The following is a description of a gene set: species: Homo sapiens Human Gene Set: GOMF_OXIDOREDUCTASE_ACTIVITY_ACTING_ON_CH_OH_GROUP_OF_DONORS Catalysis of an oxidation-reduction (redox) reaction in which a CH-OH group act as a hydrogen or electron donor and reduces a hydrogen or electron acceptor., and this is the list of marker genes: CBR3 (NCBI Gene Id 874), AKR7A2, EHHADH, RDH16, SORD, UEVLD, HSD3B2, DHRS3, NSDHL, HADHB, HSD17B1, UGDH, RDH10, ADH7, DHRS1, HSD17B8, HPGD, L2HGDH, SDR16C5, ADH1A, LDHAL6A, BDH2, CYP4F3, HIBADH, HAO1 (hydroxyacid oxidase 1), PTGR1, IDH2, CYP4F2, DHRS9, CBR4, HSD11B2, IDH3G, DHRS4L2, MDH2, ME1, ADH1C, HSD17B3, BDH1, ADH6, ADH5, KCNAB3, HSD17B10, DHRS4L1, IDH1, HSD3B1, AKR1B10, PGD, H6PD, IDH3A, IMPDH2, DHDH, GPD1, ALDH3A2, RDH13, GPD2, HSD17B2, LDHAL6B, GFUS, ME2, IMPDH1, DHRS7, MDH1B, HADHA, LDHA, DHRS4, G6PD, AKR1C2, CTBP2, ADH1B, SDR42E1, RDH14, HSD17B14, DHRS2, AKR1B15, CRYL1, HSD3B7, AKR7A3, ADH4, KDSR, HSD17B7, AKR1C1, HSD11B1, SDR42E2, CYP4A22, DHRS7B, PRXL2B, CTBP1, MLDHR, RDH8, GPD1L, CBR1, RDH11, HSD17B11, FASN, AKR1B1, MIOX, IDH3B, PHGDH, CHDH, AKR1E2, ABCC4, ME3, KCNAB1, HSD17B4, ALDH3A1, SRD5A2, SPR (sepiapterin reductase), DHRS11, AKR1A1, KCNAB2, AKR1D1, AKR1C3, RDH5, LDHC, LIPF, ADHFE1, LDHD, DHRS7C, HADH, AKR7L, GRHPR, HSD17B13, HSD17B12, SDR9C7 (NCBI Gene Id 121214), RDH12, D2HGDH, HMGCR, HSD17B6, AKR1C4, DCXR, LDHB (NCBI Gene Id 3945), MDH1, HAO2